The following is a description of a gene set: species: Mus musculus The chemical reactions and pathways involving erythrose 4-phosphate/phosphoenolpyruvate family amino acid. Mouse Gene Set: GOBP_ERYTHROSE_4_PHOSPHATE_PHOSPHOENOLPYRUVATE_FAMILY_AMINO_ACID_METABOLIC_PROCESS, and this is the list of marker genes: Ido2, Oca2, Nadsyn1, Qprt, Acmsd, Nmnat2, Kynu, Hpd, Gstz1, Spr, Slc45a2, Gcdh, Iyd, Ttc36, Th, Afmid, Ido1, Kmo, Tyrp1 (NCBI Gene Id 22178), Haao, Pcbd1, Tat, Dct, Fah, Tdo2, Pcbd2, Thap4, Atp7a, Hgd, Il4i1, Qdpr, Pah